The following is a description of a gene set: studied in species Homo sapiens Increased width of nail. Broad nail Human Gene Set: HP_BROAD_NAIL, and this is the list of marker genes: IHH, TRAF3IP2, IL17F, HPGD, FHL1, IFT43, IKBKG, CLEC7A, IL17RA, IL17RC